Given this list of marker genes MRPS31, RORC, MLH1, GPSM2, ADD1, CIT, CYP1B1, MET, REV3L, GLOD4, NLRP1, PIGCP1, MAP2K5, NLGN4Y (NCBI Gene Id 375846), AHNAK2, TRAF3IP3, GSTT4, CLUAP1 (clusterin associated protein 1), ETFB, BLVRB, DYNC2LI1, PRKCE, PDPN, FARS2, HLA-DOA (NCBI Gene Id 51034), SLC6A15, CCNB2, PIK3CD, ADA, IRS1, BTN3A2, PDE5A, PSMG1, PCLAF, ALMS1, PDGFRA, DENND2B, FAH, PSMB10, CRADD, LPAR1, NDUFS2, WWP2, CAND2, SOCS1, CDH13, SKIC2, PRRX1 (NCBI Gene Id 5396), PLAUR, DTYMK, CHML, SMAD6, MPI, GNG11, PLA2G5, ABCC1, RIPOR2, SLITRK5, SYNE1, SGSM3, SGCD, ERCC2, GAS1, TRAF3IP2, IRF2, BCKDHB, GLRX (NCBI Gene Id 90885), BTN3A3, AP3S2, ASL, DKK1, NIPBL, OCA2, APPBP2, FAS, BUB1B, THPO, S100A3, NPTX1, ZFP36L1, TRAK1, SLC10A2, HNRNPU, HSPA4, DESI1, NDUFAF1, RRAS2, TM7SF2, LMNA, ZNF135, NDC80, AMOT, AP4M1, TTF2, CPSF1, UNC93A, SMAD3, RRAS, HMMR, TOX, ATG5, IL12B, SPN, TMCO6 (transmembrane and coiled-coil domains 6), CDC25B (cell division cycle 25B), HOXA11, DDX17, MECOM, RIOX2, ZNF7, SPTB, AGGF1, PARP4, NIT1, ADH1C, SGCB, ATP2A2, AKAP13, TULP3, LIMK2, SMS, BLK, MYO10, CEBPD (CCAAT enhancer binding protein delta), SMARCE1, NOTCH2 (notch receptor 2), ZNRF4, CA5A, DST, SLC25A12, FGF2 (fibroblast growth factor 2), TP53I3, DHFR, G0S2, MNAT1, SERPINE1, PDE4DIP, SIRPA, HSPB3, N4BP3, RAD50, STAMBP, TAF1B, TK1, LAMC2, MAGEA10, FOXF2, PLPP3, SLC16A2, SLC24A1, AQP4, TJP1, EEA1, PTGER1 (NCBI Gene Id 5731), ERBB2, VPS41, MYO1B, VAMP4, GINS1, ITGA2, RBM10, RAB27B, NEK1, ABCA2, EIF3J, LPXN, NR1D2, BAX, HMBS, CLDN4, TIA1, RAB1A, TCF7L2 (NCBI Gene Id 6934), INPP4B, DYRK4, JCAD, PLAU, PLCD1, HAS2, CDC14B, CDH6, RGS20, SYNJ2, ME3, WNT5A, DMAC2L, PRSS12, ZFR, EPPIN, ARHGEF17, CHEK2, CZIB, PRKAB2 (NCBI Gene Id 5565), UBL3, GJA4, EXT1, NORAD, MMP3, FSCN2, RASA2, RUFY3, MTCP1, ANXA2, ACAT2, MTIF2, NDUFB7, PLEC, ZKSCAN1, VEGFC, ADGRL2, H4C3, CASP1, DIAPH2, MGMT, FGF13, CENPE, MT1F, H2AC13, MIPEP, JADE2, BMX, GALE, GSTT2, HOXB1, CRYBG1, PAPSS2, CMAHP, NUMA1, MVP, DTNA, MT1A, STC2, GRK5, RHOBTB3, PEX6, SPAG9, HIPK2, EGFR, CCDC22 (NCBI Gene Id 28952), MT1E, DELE1, ITPKA, TUBA3C, ZFP36L2, TIAL1, NNMT (nicotinamide N-methyltransferase), MICAL2, ITGA3, TPM2, RBPMS, AXL (NCBI Gene Id 558), GLT8D1, ETV1, LDLR, SLC14A2, RBMS3, ERG28, HIC1, THBS1, H4C9, NIPAL3, ZCCHC24, CXCL13, CAP2, ZNF205, CCL2, PSMD4, DYNC1I2, NEUROD1, FGF7, TRIO, NR1H3, SIPA1, ACKR3, DENND3, CEP290, APOBEC3B, ERLIN2, ERCC6, ACOX1, MARCKS, AGFG1, OLFM4, ADD3, MMP16, HNRNPDL, PDE1C, STON1, TERT, EIF3A, here is a description of the gene set: The effect of human cytomegalovirus (HCMV) infection on cellular mRNA accumulation was analyzed by gene chip technology. During a 48-h time course after infection of human diploid fibroblasts, 1,425 cellular mRNAs were found to be up-regulated or down-regulated by threefold or greater in at least two consecutive time points. Several classes of genes were prominently affected, including interferon response genes, cell cycle regulators, apoptosis regulators, inflammatory pathway genes, and immune regulators. The number of mRNAs that were up-regulated or down-regulated were roughly equal over the complete time course. However, for the first 8 h after infection, the number of up-regulated mRNAs was significantly less than the number of down-regulated mRNAs. By analyzing the mRNA expression profile of cells infected in the presence of cycloheximide, it was found that a minimum of 25 mRNAs were modulated by HCMV in the absence of protein synthesis. These included mRNAs encoded by a small number of interferon-responsive genes, as well as beta interferon itself. Cellular mRNA levels in cytomegalovirus-infected cells were compared to the levels in cells infected with UV-inactivated virus. The inactivated virus caused the up-regulation of a much greater number of mRNAs, many of which encoded proteins with antiviral roles, such as interferon-responsive genes and proinflammatory cytokines. These data argue that one or more newly synthesized viral gene products block the induction of antiviral pathways that are triggered by HCMV binding and entry. studied in species Homo sapiens from publication Browne EP, Wing B, Coleman D, Shenk T (PMID 11711622) Human Gene Set: BROWNE_HCMV_INFECTION_14HR_DN Genes down-regulated in primary fibroblast cell culture after infection with HCMV (AD169 strain) at 14 h time point that were not down-regulated at the previous time point, 12 h.